Given this list of marker genes AGO2, TLR7, MBD2, MECP2, TARBP2, ARB2A, ARB2BP, PRKRA, DHX9, TLR9, FMR1, DICER1, here is a description of the gene set: studied in species Homo sapiens Human Gene Set: GOMF_SIRNA_BINDING Binding to a small interfering RNA, a 21-23 nucleotide RNA that is processed from double stranded RNA (dsRNA) by an RNAse enzyme.